The following is a description of a gene set: species: Homo sapiens The directed killing of a target cell by a T cell through the release of granules containing cytotoxic mediators or through the engagement of death receptors. Human Gene Set: GOBP_T_CELL_MEDIATED_CYTOTOXICITY, and this is the list of marker genes: LILRB1, NCKAP1L, HLA-DRB1, CTSH, RAET1G, CADM1, RAB27A, CD1E, KLRC1, PPP3CB, IL12A, HPRT1, HLA-E, HLA-G, HLA-A, HLA-B (NCBI Gene Id 730410), CRTAM, ULBP2, PRF1, STX7, FCGR2B, GZMM, XCL1, HLA-C, CD1B, PTPRC, IL12B, KLRD1, ULBP1, FADD, MICA, HLA-F, RIPK3, HLA-H, P2RX7, CD1C, PVR, IL23A, CEACAM1 (CEA cell adhesion molecule 1), EBAG9, AZGP1, NECTIN2, GFUS, CYRIB, IL12RB1, EMP2, TAP2, IL7R, CD1A, ULBP3, AGER, SLC22A13, RAET1E, MR1, CD1D, IL23R, CTSC, B2M, HLA-DRA, RAET1L